Given this list of marker genes Bmp5, H6pd (hexose-6-phosphate dehydrogenase (glucose 1-dehydrogenase)), Dgkq, Cyp11b1, Stub1, Cacna1h, Nr3c1, Cyp17a1, Cbr1b, Cbr1, Dkk3, Bmp2, Apoa1, Hsd11b2, Mecp2, Ywhah, Star, Rest, Cyp21a1, Crh, Cyp11b2, Gal, Serpina6, Abcc1, Hsd11b1, Cyp11a1, Atp1a1, Wnt4, Nr5a2, here is a description of the gene set: studied in species Mus musculus The chemical reactions and pathways involving glucocorticoids, hormonal C21 corticosteroids synthesized from cholesterol. Glucocorticoids act primarily on carbohydrate and protein metabolism, and have anti-inflammatory effects. Mouse Gene Set: GOBP_GLUCOCORTICOID_METABOLIC_PROCESS